The following is a description of a gene set: studied in species Homo sapiens Any process that stops, prevents or decreases the rate of addition of phosphate groups to a molecule. Human Gene Set: GOBP_NEGATIVE_REGULATION_OF_PHOSPHORYLATION, and this is the list of marker genes: PRDX3, CACTIN, HEG1, SFRP2, CIB1, ZBED3, DNAJC3, ATG14, PRR5L, GADD45A, TAF7, SNX6 (sorting nexin 6), PPIA (peptidylprolyl isomerase A), DBNDD2, MYCNOS, PRKDC, PARP14, PTPN22, PAK2, MAPK8IP1, KLHL31, STK38, CDKN1A, NPM1, ADAR, AGT (angiotensinogen), CEACAM1, IGFBP3, SFN, CDKN1B, THY1, HIPK3, NPRL2, CDK5RAP1, DNAJA1, CDKN2A (cyclin dependent kinase inhibitor 2A), INSM1, PDCD4, CORO1C, ITGB1BP1, YWHAG, AKT1S1, PTPRC, ZFYVE28, LATS1, CD300A, RTRAF, PRKCH, NLRP2B, TRAF3IP1, TSG101, PTPN1, SOCS4, SOCS5, CEP85, NIBAN1, INCA1, GPRC5A, INHA, ANKLE2, APOE, PPP1R15B, CHMP6, SLIT2, SFRP1, RGS14, FBLN1, ADIPOQ, SIRT1, NT5DC2, ADARB1, SIRT2, MEN1, AIDA, PPM1E, PRKN, SAMSN1, VPS25, SRCIN1, MACROH2A1, RB1, SERPINB3, ZC3H12A, PTPN13, INPP5F, CEP43, CDKN1C, CDK5RAP3, RASSF2, GCKR (glucokinase regulator), GSKIP, DEFB114, PKIA, SMO, MIDN, PTPRJ, FKBP8, CNKSR3, DUSP7, C9orf72, DEPTOR, HNRNPU, PTEN, WARS1, TARBP2, DMTN, APC, LYN, TERF2IP, PARD3 (NCBI Gene Id 56288), PAQR3, RASIP1, CADM4, IBTK, NPPA, TRIM27, MVP, ERRFI1, TARDBP, TFAP4, DYNLL1, CHP1, LATS2, PIBF1, PTPN2, ACP4, PYCARD, ZGPAT, INHBA, PTK6 (protein tyrosine kinase 6), DUSP1